The following is a description of a gene set: A structural anomaly of the trachea. Abnormal tracheal morphology species: Homo sapiens Human Gene Set: HP_ABNORMAL_TRACHEAL_MORPHOLOGY, and this is the list of marker genes: FANCA, FGF20, RPL5, SMAD4, SCAF4, PAX3, WBP11, ELN, FKBP6, FBN2, PROKR2, GTF2IRD1, PALB2, RET, NOP10, RFWD3, MYRF, ADAMTSL2 (NCBI Gene Id 9719), WNT7A, LMBRD1, KCNJ10, POLR1B, PCNT (pericentrin), XRCC2, ORC6, SALL1, SCUBE3, HESX1, CLIP2, HOXD13, FOXF1, FGFR2, KIF22, ZIC3, TYMS, SOX2, METTL27, RAD51, FANCE (FA complementation group E), WNT9B, CYBB, ZNF699, PDGFRB, SLC12A2, MAP3K7, CHD6, FREM2, CHD7, GTF2I, RTEL1, RAD51C, MYCN, NCF4, TMEM270, WNT3, TRRAP, IDS, CYBC1, DDRGK1, FAT4, HYLS1, POLA1, RAB3GAP2, SOX9, GMNN, RSPO2, NHP2, B3GALT6, SLC26A2, GTF2IRD2, ARNT2, KMT2C, POLR1C, BMPER, AHDC1, VPS37D, TRIM2, PAICS, HRAS, NPM1, USP9X, SLX4, SNRPB, SEMA3E, DCHS1, BUD23, LTBP3, RAP1B, STX1A, EBP, WRAP53, KANSL1, POLG, TBL2, SLC26A4, FANCG, NCF2, DNAJC30, WDR26, FANCI, LIMK1, BAZ1B, HK1, ITGA8, BRCA2, AMER1, BRIP1 (BRCA1 interacting helicase 1), KIF7, PARN, COL2A1, ERCC4, FGFR1 (NCBI Gene Id 84151), RALGAPA1, CEP295, MAD2L2, LBR, POLR1A, NOTCH3, RFC2, CTC1, DDR2, ERF (ETS2 repressor factor), ZEB2, TERT, FOXI1, UBE2T, USB1, ESAM, UBA2, DHCR7, TBX4, FANCB, SOX3, HDAC4, GFRA1, POLR1D, SETD2, TONSL, FANCF, ORC4, FANCC, AFF4, CYBA, LTBP4, TINF2, RAC1, EXTL3, FANCD2, FANCM, GRIP1, BUB1, MID1, DKC1, ARSL, FLNB, BRCA1, IDUA, PRRX1, EHMT1, OTX2, GLMN, GREB1L, FRAS1, FANCL, TERC, MGP, EIF4H, EMC1, RMRP, NCF1, TCOF1